The following is a description of a gene set: from publication Chen Y, Wang X (PMID 31504780) species: Mus musculus Mouse Gene Set: MIR_505_5P Genes predicted to be targets of miRBase v22 microRNA mmu_miR_505_5p in miRDB v6.0 with MirTarget v4 prediction scores > 80 (high confidence targets)., and this is the list of marker genes: Mtcl2, Vamp3, Rnpepl1, Ugt3a2, Esr1, Rasd2, Cfap96, Fbxl22, Ptdss2, Amotl2, Plpp5, Magohb, Slc8a3, Akap11, Slc48a1, Hpgds, Cdk5, Fgfr3, Zfp748, Mtf1, Kat7, Ttc41, Glis2, Nr5a1, Alx1, Chrna2 (NCBI Gene Id 211701), Ubqln4, Smagp, Ercc4, Sdc3, Gnao1, Dtx4, Arl5b, Ccr4, Ddx3x, Hipk3, Dennd6b, Gdi2, Snph, Emg1, Gpc6, Alg10b, Spock1, Ehd2, Avpr2, Xaf1, Hpcal1, Nck2, Mr1, Mga, Aasdhppt, Crebl2, Mecp2, Adcy1, Myadm, Kpna1, Lrrc55, Acp2, Myrf, Sf1, Sv2b, Oit3, Dlg2, Retreg3